The following is a description of a gene set: Mouse Gene Set: GOBP_LYMPHOID_PROGENITOR_CELL_DIFFERENTIATION studied in species Mus musculus The process in which a precursor cell type acquires the specialized features of a lymphoid progenitor cell. Lymphoid progenitor cells include progenitor cells for any of the lymphoid lineages., and this is the list of marker genes: Flt3, Notch1, Prkdc, Xrcc4, Sos2, Fnip1, Hes5, Zbtb1, Pcid2, Kit, Flcn, Hmga1, Shh, Trex1, Spi1 (NCBI Gene Id 20375), Gata3, Batf, Sox4, Sos1, Hes1, Ankle1 (ankyrin repeat and LEM domain containing 1), Gm36723, Nudt21, Bmp4, Znhit1, Lig4, Bcl2